Given this list of marker genes Noxa1, Noxo1, Pdgfb, Ncf2, Ncf1, Ncf4 (NCBI Gene Id 193645), Sh3pxd2a, Sh3pxd2b, here is a description of the gene set: species: Mus musculus Binds to and increases the activity of the enzyme superoxide-generating NADPH oxidase. Mouse Gene Set: GOMF_SUPEROXIDE_GENERATING_NADPH_OXIDASE_ACTIVATOR_ACTIVITY